Given this list of marker genes NRAS, SOS1, KDR, HRAS, BIN2, ETV6, PIK3CA, PDGFRA, GRB2, KANK1, FIP1L1, PIK3R2, WDR48, PIK3R1, STAT3, PIK3CB, GOLGA4, STAT1, STRN, KRAS, here is a description of the gene set: Signaling by PDGFR in disease species: Homo sapiens Human Gene Set: REACTOME_SIGNALING_BY_PDGFR_IN_DISEASE